The following is a description of a gene set: studied in species Homo sapiens Genes differentially expressed between PDX and donor tumor samples from nine ovarian cancer patients. from publication Liu Y, Chanana P, Davila JI, Hou X, Zanfagnin V, McGehee CD, Goode EL, Polley EC, Haluska P, Weroha SJ, Wang C (PMID 31004097) Mouse Gene Set: LIU_OVARIAN_CANCER_TUMORS_AND_XENOGRAFTS_XDGS_UP A bioinformatics pipeline to separate donor tumor and mouse stroma transcriptome profiles was devised and tested. To examine the molecular fidelity of PDX versus donor tumors, the authors compared mRNA differences between paired PDX-donor tumors from nine ovarian cancer patients., and this is the list of marker genes: Foxi3, Adgrl1, Palm3, Ksr2, Rnft2 (ring finger protein, transmembrane 2), mt-Ts2, Mkrn3, Lcn10, Cplx2, Ly6g5b (lymphocyte antigen 6 family member G5B), Pax2, P2ry2, mt-Tl2, Clspn, Pgam1, Ticrr, Hsp90ab1, Dlx4, mt-Th, Xkr7, Ggt1, Ssu2, Cngb1, Pomk, Pif1, AI480526, Kif12, Id1, Grin2b, Map3k9, Csnk2a1, Washc1, Kcnh3, Plxna4, Troap, Siah3, Disp3, Mki67, Kifc5b, Ovol1, Skida1, Ccnf, Prox2, Fgb, Haspin, Eif3c, Ninl, Kif18b, Pacsin1, Rassf10, Recql4, Afg3l1, Nectin1, Cysrt1, Rd3, Jrk, Mgat5b, Obscn, Gm23187, Ramac, Igsf23, Slc28a2b, Dact2, Lhx4, Rab6a, Celsr3, Nat8l, Chchd2 (coiled-coil-helix-coiled-coil-helix domain containing 2), Tmem183a, Adra1b, Rap1gap2, Cit, Alpl, Pabpc6, Mybl2, Ank1, Sptbn5, Snrpg, Rcor2, Anxa2, Foxb1, Ddx11, Espl1, Sbk2, Wdr62, Cldn9, Sult1a1 (NCBI Gene Id 20887), Clcnkb, Myom3, Tgm7, Spag5, Ccdc150